The following is a description of a gene set: species: Homo sapiens Nef Mediated CD8 Down-regulation Human Gene Set: REACTOME_NEF_MEDIATED_CD8_DOWN_REGULATION, and this is the list of marker genes: AP2A2, AP2B1, CD8B, AP2M1, AP2A1, AP2S1, ATP6V1H